Given this list of marker genes DDX6, NSUN2, TDRD7, PIWIL1, EIF4E, DDX25, CLOCK, BMAL1, MAEL, TDRD6, TDRD1, PIWIL2, SMG1, TDRD5, here is a description of the gene set: A ribonucleoprotein complex found in the cytoplasm of male germ cells, composed of exceedingly thin filaments that are consolidated into a compact mass or into dense strands of varying thickness that branch to form an irregular network. Contains mRNAs, miRNAs, and protein components involved in miRNA processing (such as Argonaute proteins and the endonuclease Dicer) and in RNA decay (such as the decapping enzyme DCP1a and GW182). Human Gene Set: GOCC_CHROMATOID_BODY studied in species Homo sapiens